The following is a description of a gene set: A sudden flexion, extension, or mixed extension-flexion of predominantly proximal and truncal muscles that is usually more sustained than a myoclonic movement but not as sustained as a tonic seizure. Limited forms may occur: Grimacing, head nodding, or subtle eye movements. Epileptic spasms frequently occur in clusters. Infantile spasms are the best known form, but spasms can occur at all ages Epileptic spasm Human Gene Set: HP_EPILEPTIC_SPASM species: Homo sapiens, and this is the list of marker genes: MT-TK, KCNB1, ASPA, SETBP1, MT-ND6, UFSP2, NGLY1, ATP6V0C, CAPRIN1, ATP6V0A1, SLC2A1 (NCBI Gene Id 6513), MTOR, MT-TL1 (mitochondrially encoded tRNA-Leu (UUA/G) 1), PTPN23, NEUROD2, PPIL1, ADGRG1, ST3GAL3, SMARCA2, GNAQ (NCBI Gene Id 2776), DPAGT1, ERCC5, SCN1A, ALG2, EEF1A2, TBC1D24, GRM7, SCN8A, SUCLA2, CDC40, GABBR2, SLC32A1, MDH2, EHMT1, VPS53, STAMBP, CUL3 (cullin 3), ATAD1, TUBG1, CACNA1B, TSEN34, FBLN1, MFF, DEPDC5, TRPM3, FBXL4, TBL1XR1, ATP6V1A, DOCK7, GRIN2B, PCDH12, MGAT2, GCDH, GCSH, ERMARD (NCBI Gene Id 55780), ACTL6B, CDK19, CRELD1, SCN1B, ACBD6, ATP1A3, PIK3CA, ZNHIT3, MT-TV, AP2M1, PHGDH, MT-ND5, ZNF526, MAPK1, DOLK, SLC25A22, NTNG1, NPRL3, TSEN2, RUSC2, GUF1, MACF1, NEDD4L, CDKL5, CHD2, SMC1A, TSEN15, NTRK2, PHACTR1, PURA, PRUNE1, ARFGEF1, KCNH5, TSC1, DCX, SLC12A5, KCNC2, D2HGDH, PLCB1, SCN2A, STRADA, CDH2, SLC6A1, TUBB2A, GAD1, LONP1, SLC25A10, SLC1A4, DMXL2, CNTNAP2, RNU4ATAC, RALGAPA1, ALG14 (ALG14 UDP-N-acetylglucosaminyltransferase subunit), NACC1, ALDH7A1, UBA5, PIGP, TUBB3, BTD, TSEN54, ATP2B1, CEP85L, NPRL2, CNPY3, STXBP1, RNF13, EIF4A2, DNM1, SRPX2 (sushi repeat containing protein X-linked 2), SLC35A2, OTUD7A, CASK, GNAO1, PI4KA, MECP2, GNB1, WDR45 (WD repeat domain 45), CPLX1, PLPBP, MMACHC, TRIM8, KDM4B, GOLGA2, HCFC1, GABRB3, PPFIBP1, SYNJ1, KCNT1, TRAPPC12, TUBB2B, MT-ND3, PNKP, TUBA1A (NCBI Gene Id 95407), DHX16, SEPSECS, SPTAN1, PDHA1, AFG2A, KCNT2, UFC1, WWOX, GRIK2, PSAT1, MT-ND2, CLCN4, NAXD, IFNG, KCNQ2, MT-ATP6, POLR1A, GLUL, CTNNA2, GRIN2A, HK1, HDAC4 (NCBI Gene Id 9759), SYNGAP1, ARX, MT-TW, ASAH1, TSC2, AFG2B, PRRT2, GABRA3, AKT3 (AKT serine/threonine kinase 3), HIBCH, CHD3, PI4K2A, COX4I1, NDUFAF8, ATP7A, NSF, FBXO28, DHX37, MT-ND4 (NCBI Gene Id 4538), SLC19A3, APC2, KCNQ5, GRIN1, TUBA8, SPTBN1, PIGA, SLC1A2, NEXMIF, ALG13, TANGO2, TIMM50, SIK1, UGDH, PPP3CA, GABRG2, NCDN, TBCD, CELF2, PIGQ, MT-ND1, KCNA1, PAFAH1B1